Given this list of marker genes Cdk5, Dpysl2, Crmp1, Plxna3, Fyn, Fes, Dpysl5 (NCBI Gene Id 65254), Dpysl3, Sema3a, here is a description of the gene set: This event has been computationally inferred from an event that has been demonstrated in another species.<p>The inference is based on the homology mapping from PANTHER. Briefly, reactions for which all involved PhysicalEntities (in input, output and catalyst) have a mapped orthologue/paralogue (for complexes at least 75% of components must have a mapping) are inferred to the other species. electronically inferred by orthology from the curated human pathway part of: Semaphorin interactions Reactome Pathway: CRMPs in Sema3A signaling species: Mus musculus